The following is a description of a gene set: species: Mus musculus Mouse Gene Set: GOMF_CARBOHYDRATE_PHOSPHATASE_ACTIVITY Catalysis of the reaction: carbohydrate phosphate + H2O = carbohydrate + phosphate., and this is the list of marker genes: G6pc2, Pfkfb1, G6pc3, Pfkfb3, G6pc1, Tigar, Impa2, Impa1, Pfkfb4, Epm2a, Fbp2, Fbp1, Pfkfb2